The following is a description of a gene set: Impairment of the complex regulatory network of cell death and survival is frequently the reason for therapy resistance of breast cancer cells and a major cause of tumor progression. We established two independent cell lines from a fast growing mouse breast tumor (WAP-SVT/t transgenic animal). Cells from one line (ME-A cells) are sensitive to apoptotic stimuli such as growth factor depletion or treatment with antitumor agents (e.g. doxorubicin). Cells from the second line (ME-C cells), which carry a missense mutation at the p53 codon 242, are very insensitive to apoptotic stimuli. Co-cultivation experiments revealed that the ME-C cells mediate cell death resistance to the ME-A cells. Microarray and Western blot analysis showed that osteopontin (OPN) is selectively overexpressed by the ME-C cells. This glycoprotein is the most abundant protein secreted by the ME-C cells and we obtained strong indications that OPN is the main antiapoptotic factor. However, the OPN containing ME-C cell medium does not alter the expression level of pro- or antiapoptotic genes or known inhibitors of apoptosis (IAPs). Its signaling involves mitogen-activated protein kinase (MAPK)/extracellular signal-regulated kinase (ERK) kinase (MEK)1/2 as the kinase inhibitor PD98059 restores apoptosis but not the Akt inhibitor. In the ME-A cells, mitochondrial cytochrome c release occurs with and without external apoptotic stimuli. OPN containing ME-C cell medium does not prevent the mitochondrial cytochrome c release and caspase-9 processing. In serum starved ME-A cells, the OPN containing ME-C cell medium prevents caspase-3 activation. However, in doxorubicin-treated cells, although apoptosis is blocked, it does not inhibit caspase-3. This indicates that the ME-A cells distinguish between the initial apoptotic stimuli and that the cells possess a further uncharacterized control element acting downstream from caspase-3. Genes up-regulated in ME-A cells (breast cancer, sensitive to apoptotic stimuli) exposed to doxorubicin in the presence of medium concentrate (MC) from ME-C cells (breast cancer, resistant to apoptotic stimuli). species: Mus musculus from publication Graessmann M, Berg B, Fuchs B, Klein A, Graessmann A (PMID 17160024) Mouse Gene Set: GRAESSMANN_RESPONSE_TO_MC_AND_DOXORUBICIN_UP, and this is the list of marker genes: Zfp958, Hexb, C1qtnf1, Slc39a4, Lpin1, Pnp, Padi2, Gpn3, Hgsnat, Ak4, Alas1, Tuba4a, Rnf181, Zmiz2, Rnpep, Tbx2 (NCBI Gene Id 21385), Ces2g, Lrrc56, Lrrc57, Mapk9, Naa80, Dgka, Cntrl, Ly6d, Map1lc3a, Gata3, Ugt1a2, Nbeal2 (NCBI Gene Id 68604), Igtp, Klf17, Rap2a, Rnf103, Mpp4, Cpt2, Mx1, Rad9a, Pdrg1, Pitpnm2, Lactb, Fgf18, Lrr1, Galm, Phgdh, Camk2b (calcium/calmodulin-dependent protein kinase II, beta, NCBI Gene Id 12323), Dleu2, Pla2r1, Kctd12, Smim7, Mxd4, Selenos, Agtpbp1, Mmp15, Hagh, Pdlim5, Wnt7b, Impact, Cops9, Fetub, Extl1, H1f2, Abhd5, N4bp2l1, Dcaf1, Phlda3, Rbm38 (RNA binding motif protein 38), Tlr2, Zfp296, Apaf1, Ptger1, Snf8, 1700084E18Rik, Pthlh, Srr, Ankrd10, Brix1, Nanos1, Sac3d1, Arhgap27, Mafg, Leng1, Endod1, Usp17la, Efnb1, Pdgfa, Cnbd2, Mycbp, Slc12a7, Ephx1, Tor2a, Itpka, Abcb10, Fas, Gns, Plaat3, Natd1, Gsta2, Eogt, Gpsm1, Ppif, Rhod (NCBI Gene Id 11854), Plek2, Grina, Crat, Slc31a1, Dop1b, Gga2, Man2b1, Ptp4a1, Rasa4, Dexi, Armc7, Dnajc18, Cenpt, Rab40c (NCBI Gene Id 224624), Arap2, Recql4, Alox12, Twf2, Ric8a, Msantd5f5, Rab43, Tmem40, Cby1, Rnf135, Fez1, Irak1bp1, Hyal2, Tgfb3, Dusp9, Sgpp1, Ppm1a, Bmp1, Cbr2, Atp13a2, Trafd1, Sh3bgrl2, Susd6, Fam50a, Fkbp9, Nt5dc3, Gss, Lpgat1, Prkra, Sh3glb2, Tspan13, Cotl1, Lmo4, Sap18, Ift27, Frmd8, Eno2, Irgm1, Sord, Clp1, Ccs, Capg, Il15, Abtb1, Calhm2, Agpat5, Gusb, Ppm1m, Ergic3 (NCBI Gene Id 99284), Coro2a, Klhl22, Trp53inp2, Tmem41a, Pdlim1, Vasn, Pla2g6, Lman2, Atp6v0e2, Lrrc51, Rdm1, Fbxl20, Mapkbp1, Ncoa1, Ppp1r15a, Aldh4a1, Angptl2, Clba1, Lztr1, Trmt5, Dnajb1, Atp6v0d1, Mafb, Adrb2, Eola1, Celf4, Foxj1, Srf, Zfyve21, Paqr4, Wipi1, Ndrg4, Ckap2, Icam5, Tm7sf3, Ulk1 (unc-51 like kinase 1), Cracr2b, Padi1, Sh3bgrl3 (NCBI Gene Id 73723), Cd27, Hmg20b, Elapor1, Pfn2, Dolk, Cenpe, Serinc3, Tgm2, Klhl42, Nid2, Sh3yl1, Crot, Capn10, Mthfr, Aox1, Ikbke, Ttll1, Islr, Cabyr, Cdc25a, Zfp185, H2-Eb1, Mdm2, Stx3, Cbx1, Sdhaf1, Gkap1, Zfp764l1, Znrf2, Zfp703, Ripk4, Sncg, Slc6a8, Slc35a5, Lgals3bp, Crip2, Carhsp1, Dmpk, Efnb2, Fam216a, Ctsb, Psapl1, Atp6v0b, Oas1c, Cstb, Slc18a1, Stat1, Gtf2b, Pitpnm1 (phosphatidylinositol transfer protein, membrane-associated 1), Aldh2, Trex1, Hras, Pde4dip, Tmem38a, Ivd, H3c4, Mapre1, Pm20d1, Padi3, Itgb4, Cirbp, Vegfa, Zbtb8a, Dab2, Gstz1, Gsta4, Stk17b, Lbx2, Usp2, Rin2, Patz1, Srxn1, Ninj1, Rnaseh2c, Tmc6, Dcaf4, Psrc1, Ampd2, Rnf128, Ssx2ip, Dcxr, Adam8, Cdr2l, Tor3a, Tpra1, Dpp7, AI661453, Prkd2, Adamts7, Tango2, Trim32, Fdxr, Ppp2r5d, Xrcc1, Exoc4, Arl16, Etfdh, Depdc7, Fah (NCBI Gene Id 14085), Kctd10, Snx2, S100a13, Ogfrl1, Rab11fip5, Gpld1, Slc7a7, Oplah, Ppp5c, Ube2i, Tmbim1 (NCBI Gene Id 98587), Zfand2a, Flcn (folliculin), Thyn1 (thymocyte nuclear protein 1), Mmd, Daxx, Casq2, AI837181, Ccdc117, Tuft1, Cdkn1a, Polrmt, Hsd11b2, Hmox1 (NCBI Gene Id 27970), Tpp1, Mapre3, Marveld1, Procr, Cysrt1, Ptgr1, Dgkq, Tacc3, Aldh1l1, Pdk4, Higd1a, Tcstv2a, Mxd3, Prkcd (NCBI Gene Id 52581), Hsbp1 (NCBI Gene Id 68196), Lynx1, Fam43a (family with sequence similarity 43, member A), Tmem150a, Ren1, Rbm43, Tmem19, Trp53inp1, Emp3, Hsd17b4, Pkdcc, Nherf2, Tmem158, Inpp5b, Scarb1, Gpr146, Mcee, Skic8, Hspa1b, Ercc5, Ppp1r37, Acox2, S100a3, Ankrd17, Traf4, Ifitm10, Wrap53, Eif4e3, Osgin1, Ptpn11, Ddr1, Fbxo33, Ces2e, Nxn, Znrf1, Zmat3, Apoh, Abhd4, Dgat2, Rida, Apof, Pgf, Ptpn1, Ldlrap1, Fzd7, Dnajb2, Crlf1, Nudcd2, Shmt2, Tmod1, Sbk1, Slc20a1, Lif, Tnni1, Fam110a, Rusc1, Lhx2, Itga6, Pom121, Dbt, Stard5 (NCBI Gene Id 67714), Sfi1, Rxrb, Zfp281, Angpt4, Gsn, Ass1, Tepsin, Ppm1b (protein phosphatase 1B, magnesium dependent, beta isoform), Pkp3, E2f1, Nr4a1, Opn1sw, Prcp, Fam32a, Plxnb2, Coro1a, Nos3, Apobec1, Arpp21, Stoml2, Hes6, Chac1 (NCBI Gene Id 69065), Ifi30, Tmem184b, Efnb3 (NCBI Gene Id 13643), Cited4 (Cbp/p300-interacting transactivator, with Glu/Asp-rich carboxy-terminal domain, 4), Dapk1, Tspan33, Nfatc3, Hs6st1, Surf4, Stard10, Pmm1, Bcl2l11, Hhatl, Utrn, Ahnak, Perp, Atp6v1d, Idh1, Tgoln1, Gtse1, Angel1, Endog, Sp6, Dram1, Masp1, Ripor1, Ube2t, Bet1l, Slc19a2, Aamdc, Lasp1, Slc25a29 (solute carrier family 25 (mitochondrial carrier, palmitoylcarnitine transporter), member 29), Trim7, Stim1, Ldb3, Col11a2, H2ac25, Tnfrsf18, Gpat4, Unc119b, Dcbld1, Pkp1, Smox (spermine oxidase), Bcar1, Eeig1, Pdgfb, Scmh1, Tkfc, Snx16, Il18, H2-T10 (NCBI Gene Id 15024), Sidt2, Krt5, Ralgps1, Sp110, St6galnac4, Acad8, Cxcr4, Pias3, 4833445I07Rik, Rogdi, Pvalb, Jade1, Fa2h, Tbc1d8, Ufsp1, Pcyox1, Idua, Ovol1, Slc66a3, Plec, Tfcp2l1, Atox1, Gpha2, Tmem191, Msh6, Plpbp, Ccdc166, Irf6, Ptprv (protein tyrosine phosphatase receptor type V), Serpinb5, Sh2d3c, Sephs2, Klf6 (NCBI Gene Id 97911), Dnajb9, Napa, Fzd5, Alkbh4, Rfng, Ctr9, Pctp, Dnm2, Cdk18 (NCBI Gene Id 98233), Rbl2, Cul4a, Nlrx1, Edem1, Akr1b1, Purg, Gal3st1, Tcf7, Spc25, Rabgap1, Exoc8, Dffb, Tbc1d24, Ifnz, St3gal2, Ndufa11, Gdf15, Nptx1, Hoxa5, Inpp5d, Phykpl, Ei24, Rom1, Npc2, Rhpn2, Gpd1, St14, Glcci1, Efna1, Zkscan14, Nat9, Myo1h, Cd68, Mtarc2, Ehd4, Fosb, Col18a1, Scn1b, Acot6, Hpn, Sdc1, Ubald2, Glud1, Rb1, F11r, Slc37a2, Spef1, Naa35, Dph7 (diphthamine biosynethesis 7), Jup, Dnajc9, Cpox, Slc33a1, Clec4g, Spryd4, Gem, Usp17lc, Oas1d, Lancl1, Fam83h, Rpe, Uba7, Sesn2, Polk, Tinagl1, Spa17 (NCBI Gene Id 20686), Lgals9, Fbxw4, Rap2b, Pygo2, Entr1, Slc9a1, Acad11, Spon2, Btg2, 2310022A10Rik, Shisa2, Morc4, Acaa1b, Mrpl28, Msrb1, H2bc4, Trim11, Ak1, Icmt, Ece1, Plekhg6, Egr2, Cyp2f2, Pdxp, Fuca1, Ddit4l, Zfp503, Slc27a1, Il6ra (NCBI Gene Id 16194), Atg3, Pitpnc1, H3c14, Itga2b (integrin alpha 2b), Slc25a22, Ube2o, Usp20, Zfp385a, Baiap2, Rassf5, Mtfr1l, Als2, Arvcf, Nudt22